The following is a description of a gene set: Human Gene Set: MORF_PPP2R5B Neighborhood of PPP2R5B protein phosphatase 2, regulatory subunit B (B56), beta isoform in the MORF expression compendium Neighborhood of PPP2R5B species: Homo sapiens, and this is the list of marker genes: PHF10, SGPL1 (sphingosine-1-phosphate lyase 1), PPP2R5B, HOXD4, C1orf216, SLC4A3, AOC4P, COLGALT2, CAMK4, TFDP2, KRT33A, JRK, PDE6A, ACKR1, WBP4, SERPINA4, ARL3, NPFF, S100A5, TSSK2, SLC22A6, CYP11A1, MSH3, KLRC4, IL13RA1, PLEKHB1, RAD51D, DRC3, RUNX2, GMPR, RREB1, ADCY3, HNF1A, CELA2B, TBX19, TMEM26, GPATCH8, GJB5, ATP8B1 (ATPase phospholipid transporting 8B1), F2RL3, PVR, GABRB2, ARFGEF2, NR2C1 (nuclear receptor subfamily 2 group C member 1), SLC16A5, NR1I2, NR3C2, IVL, TBXT, POU6F2, TANC2, CEACAM4, ATF2, LORICRIN, DNAJC16, ABCB10, CNKSR1, GNG4, CTRL, IL11RA, LTBP4 (latent transforming growth factor beta binding protein 4), SULT4A1, PAXIP1, COQ7, JRKL, ERCC4, TMEM11, PDE4D, IL16, CRHR1, RB1CC1, PPP1R12B, CDC73, MFN1, GPR19, COL19A1, HTR1E, PAX9, AMMECR1, CDYL, SULT2B1, CADM4 (cell adhesion molecule 4), ZNF157, PTPRB, RXRG, CCL16, TRIM24, PHLDB1, GPR18, COX6A2, ZNF202, PSG1, ABO, DGCR5, POU6F1, NTNG2, IPO9, NR2F1, ITIH3, AQP7, NOS2, TIE1, EXOC4, IGKV7-3, ZP2, OR2B6 (NCBI Gene Id 26214), ELAVL2, GRIK5, CYP2E1, MC5R, ZNF133, PIK3CB, IFT27, FRYL, TBC1D22A, ERC1, CACNB1, TENM4, SLC46A3, MDM2, CYP2D6, ZBTB40, CEP162, PGM3, IL13, FGF18, EPHB2, FNTB, SLC33A1, PAX7, LPGAT1, RPS6KA5, STARD5, KRR1, ZNF33B, PRELID3A, ZNF134, ABCC8, MAGEA9, BARX2, SLC18A1, KRT2, MLLT10, CPEB3 (NCBI Gene Id 22849), ABCB9, PART1, ZBTB14, BMP10, ZBTB22, P2RY10, BRCA1, SYT5, FOSL1, FIG4, ZSCAN26, POLR2K, POFUT2, ADAM20, MPZL1, PSMF1, AFF2, ATP6V0A2 (ATPase H+ transporting V0 subunit a2), TACC2, GLE1, KRT86, NRTN, SIM2, EDIL3, TMEM184B, CMKLR2, MSL3, NHEJ1, SUPT3H